The following is a description of a gene set: Human Gene Set: GOMF_OXIDOREDUCTASE_ACTIVITY_ACTING_ON_OTHER_NITROGENOUS_COMPOUNDS_AS_DONORS_CYTOCHROME_AS_ACCEPTOR Catalysis of an oxidation-reduction (redox) reaction in which a nitrogenous group, excluding NH and NH2 groups, acts as a hydrogen or electron donor and reduces a cytochrome. species: Homo sapiens, and this is the list of marker genes: ENSG00000274276, CYB5B, MTARC1, CBS, CYB5R3